Given this list of marker genes Hapln1, Car5b, Cdk7, Meis2, Zfp113, Stmn2, Pbx3, Lats2, Icos, 4933412E24Rik, Nr1d1, here is a description of the gene set: Mouse Gene Set: MIR_1195 species: Mus musculus Genes predicted to be targets of miRBase v22 microRNA mmu_miR_1195 in miRDB v6.0 with MirTarget v4 prediction scores > 80 (high confidence targets). from publication Chen Y, Wang X (PMID 31504780)